The following is a description of a gene set: species: Homo sapiens A uniocular condition in which there is fixation of an object by a point other than the fovea. This point adopts the principal visual direction. The degree of the eccentric fixation is defined by its distance from the fovea in degrees. Eccentric visual fixation Human Gene Set: HP_ECCENTRIC_VISUAL_FIXATION, and this is the list of marker genes: PDE6H, ATF6, CNGB3, OPN1MW, GNAT2, CNGA3, PDE6C, OPN1LW, OFD1, RPGR